Given this list of marker genes Pparg, Acin1, Ifi206, Hoxa7, Ifi208, Il31ra, Fes, Ifi203, Mndal, Inpp5d, Apcs, Gmpr2, Ctnnbip1, Ifi209, Csf1, Sp3, Pde1b, Vegfa, Ifi207, Cd4, Jun, Bmyc, Thoc5, Pir, Il34, Il3, Csf2, Cdk6, Med1, Ifi203-ps, Dcstamp, Mef2c, Zbtb46, Ifi214, Foxp1, Fasn, Gpr68, Myh9, Bmp4, Cd74, Myc, Ifi213, Zfp36l1, here is a description of the gene set: Mouse Gene Set: GOBP_MONOCYTE_DIFFERENTIATION species: Mus musculus The process in which a relatively unspecialized myeloid precursor cell acquires the specialized features of a monocyte.